The following is a description of a gene set: species: Mus musculus Human Gene Set: MIKKELSEN_ES_LCP_WITH_H3K4ME3_AND_H3K27ME3 We report the application of single-molecule-based sequencing technology for high-throughput profiling of histone modifications in mammalian cells. By obtaining over four billion bases of sequence from chromatin immunoprecipitated DNA, we generated genome-wide chromatin-state maps of mouse embryonic stem cells, neural progenitor cells and embryonic fibroblasts. We find that lysine 4 and lysine 27 trimethylation effectively discriminates genes that are expressed, poised for expression, or stably repressed, and therefore reflect cell state and lineage potential. Lysine 36 trimethylation marks primary coding and non-coding transcripts, facilitating gene annotation. Trimethylation of lysine 9 and lysine 20 is detected at satellite, telomeric and active long-terminal repeats, and can spread into proximal unique sequences. Lysine 4 and lysine 9 trimethylation marks imprinting control regions. Finally, we show that chromatin state can be read in an allele-specific manner by using single nucleotide polymorphisms. This study provides a framework for the application of comprehensive chromatin profiling towards characterization of diverse mammalian cell populations. Genes with low-CpG-density promoters (LCP) bearing the bivalent histone H3 trimethylation mark at K4 and K27 (H3K4me3 and H3K27me3) in embryonic stem cells (ES). from publication Mikkelsen TS, Ku M, Jaffe DB, Issac B, Lieberman E, Giannoukos G, Alvarez P, Brockman W, Kim TK, Koche RP, Lee W, Mendenhall E, O'Donovan A, Presser A, Russ C, Xie X, Meissner A, Wernig M, Jaenisch R, Nusbaum C, Lander ES, Bernstein BE (PMID 17603471), and this is the list of marker genes: SLC17A7, GAL3ST4 (NCBI Gene Id 94697), CDH7, STRA6, BTBD17 (BTB domain containing 17), FUT7, SLC16A8